Given this list of marker genes HYAL2, HYAL3 (NCBI Gene Id 8372), MAP3K20, MFAP4, CDKN1A, MAPK11, STK11, CRIP1, MME, HYAL1, MAPK14, NLRP1, here is a description of the gene set: studied in species Homo sapiens Human Gene Set: GOBP_CELLULAR_RESPONSE_TO_UV_B Any process that results in a change in state or activity of a cell (in terms of movement, secretion, enzyme production, gene expression, etc.) as a result of a UV-B radiation stimulus. UV-B radiation (UV-B light) spans the wavelengths 280 to 315 nm.